The following is a description of a gene set: species: Homo sapiens Any process that modulates the rate, frequency, or extent of epithelial to mesenchymal transition. Epithelial to mesenchymal transition where an epithelial cell loses apical/basolateral polarity, severs intercellular adhesive junctions, degrades basement membrane components and becomes a migratory mesenchymal cell. Human Gene Set: GOBP_REGULATION_OF_EPITHELIAL_TO_MESENCHYMAL_TRANSITION, and this is the list of marker genes: MCRIP1, POFUT2, MIR221, RGCC, BCL9L, MDK, MIR29B1, KDM1A, MIR144, MIR573, FOXA1, KAT8, MIR204, ZNF750, BAMBI, HPN, MIR18A, SPRY1, FBXO11, MTOR, ADIPOR1, APLF, CTNNB1, DSG2, SDHAF2, GREM1, CRB2, SPRED2, GSK3B, ENG, OLFM1, VASN, MIR519D, SERPINB3, DAB2, NKX2-1, EFNA1, MIR142, HDAC2, MIR372, JAG1, SMAD2, IL17RD, QKI, MAD2L2, MIR202, LOXL2, EMP2, TCF7L2 (NCBI Gene Id 6934), SMAD7, SNAI1, AXIN2, MIR19B1, SMAD3, TWIST1, ACVR1, ADAM8, TGFB2, AGT, ALX1, NOG, PDPN, SDCBP, MIR379, TGFBR2, TGFB1I1 (transforming growth factor beta 1 induced transcript 1), MIR145, MIR222, SPSB3, IL6, FERMT2, TBX20, COL1A1, ELL3, GCNT2, MIR302B, EZH2, BMP5, WWTR1, ZNF703 (zinc finger protein 703), SPRY2, FUZ, FOXA2, PTEN, TNXB, OVOL2, PTK2, TGFB3, VEGFA, TBX5, USF3, FOXC1, BMP2, SPRED1, EPHA3, LRG1, PPP2CA, SFRP1, MIR130A, TIAM1, DAB2IP, LDLRAD4, MIR19A, MIR21, EPHA4, BMP7, SFRP2, SPRED3, GATA3, DACT3, BMP4, IL1B (interleukin 1 beta, NCBI Gene Id 3553), NOTCH1, SMAD4, TGFB1, MIR590, ISL1, LEF1 (NCBI Gene Id 51176), TGFBR1, MIR149, GLIPR2, MARK1, TRIM62